The following is a description of a gene set: Human Gene Set: REACTOME_REGULATION_OF_CDH11_FUNCTION Regulation of CDH11 function studied in species Homo sapiens, and this is the list of marker genes: CTNNB1 (catenin beta 1), JUP, ADAM33, AMOT, CTNND1, CTNNA1, ANGPTL4, CDH11 (cadherin 11), ADAM19, CDH24, CDH8